Given this list of marker genes PES1, CHD2, PHYHD1, RASSF2, HSD17B11, LTA, RASAL1, GRAMD2B, STARD4, CTNNAL1, RIN2, UPF3B, ALS2, EMX2OS, ZPBP2, CSRNP1, CAT, HELZ2, CRIP3, ABCE1, THRSP, STAMBPL1 (NCBI Gene Id 57559), RHBDF2, APOBEC2, MZB1, PNISR, MPEG1, SREBF2, IFT74, THEM6, FASTKD2, MRPL1, NKIRAS2, ABCA5, PKD1, HSD17B7, CHST1, BPHL, CDKL3, MAP3K20, ANKRD28, TSTD1, LAS1L, CLDN10, CLUAP1, TMEM242, LIX1L, PMEPA1, RHOBTB1 (NCBI Gene Id 9886), PGPEP1L, CFAP141, WDFY4, CD72, WIPI2, BAHD1, PARD3, METTL17, RGMB, RNF19B, TSPAN13, EPS8L1, TFAP2E, ADAMDEC1, KIF12, TENM4, SRPX2 (NCBI Gene Id 27286), ZFP36L1, LRRC19, CDC26, TBC1D14, TMEM231, OOSP2, SNX9, CEP170B, CPVL, SYK, FGGY, ZNF608 (zinc finger protein 608, NCBI Gene Id 57507), ATP7B, SLC15A4, PRDM9, TERF2, TFRC, DCLK2, SCN2B, SLC43A1, CPN1, GRK4, HSDL1, SMYD5 (NCBI Gene Id 10322), SEMA4B, HIF1A, ERO1B, SLC39A11, FAM83G, ZNF516, KLHL35, PELP1, MEF2C, C9orf85, ZMYM3, P2RX4, MYO1C, PLIN3, FBXO43, PRNP, HBB, BIRC3, C19orf48P, PAN2, AKAP7, CRISP3, C1orf159, RFLNA, PDXK, ARX (NCBI Gene Id 619216), TLR3 (toll like receptor 3), NDUFA9, KRTAP20-2, PIGR, RFTN1, RFC1, SLC25A19, LPXN, DENND6A, MFSD12, MYO1E, MAP3K14, ABHD15, KCNMB4, MRPS18B, MYOM1, CD5, SOX12, UNK, CXCL13, TXNDC16, PCP4, DDX18, PCK2, INSIG1, LIPT1, KRT222, NFKBIE (NFKB inhibitor epsilon), EGFL6, STAU2, CDIP1, DERL3, SIRT4, ABHD17B (NCBI Gene Id 51104), ARPC5L, WASHC4, BDH1 (NCBI Gene Id 622), TNS3, GGT6, EGR3, LDHC, GNGT2, OVGP1, VAV2, DDX59, XXYLT1, MYBPC2, IRGM, CTH, PRDM16, SPNS3, CYP27A1, UROS, TSPO2, SYT6, GRB2, PLCG1, SLC29A3, MYCBP2, STT3B, MINDY1, AKR7A2, PNO1, DMAC2, CATSPER2, KIAA0825, NOTCH2, RBM19, MYOF, AK2, CACNA1E, FST (follistatin), NCF1 (NCBI Gene Id 653844), NSF, ALDOC, STX1A, UAP1, ANKRD49, RCCD1, GCFC2, CCDC9, LPGAT1, MICU1, here is a description of the gene set: Human Gene Set: GSE11961_MARGINAL_ZONE_BCELL_VS_GERMINAL_CENTER_BCELL_DAY7_UP To obtain insight into the genetic basis of the increase of functional activity of memory B cells over time, we compared the gene expression profiles of day 7 and day 40 NP-specific/IgG1 memory B cells, GC B cells and plasma cells in immunized WT mice and naïve B cells, before and after activation in vitro. studied in species Homo sapiens Genes up-regulated in marginal zone B cells versus day 7 germinal center B cells. from publication Kaji T, Ishige A, Hikida M, Taka J, Hijikata A, Kubo M, Nagashima T, Takahashi Y, Kurosaki T, Okada M, Ohara O, Rajewsky K, Takemori T (PMID 23027924)